The following is a description of a gene set: species: Mus musculus Mouse Gene Set: GOBP_RESPONSE_TO_UV_C Any process that results in a change in state or activity of a cell or an organism (in terms of movement, secretion, enzyme production, gene expression, etc.) as a result of a UV-C radiation stimulus. UV-C radiation (UV-C light) spans the wavelengths 100 to 280 nm., and this is the list of marker genes: Map3k4, Wrn, Brca2, Poli, Hmgn1, Dcun1d3, Ei24, Bak1, Pierce1, Trp53, Mdm2, Yy1, Polh, Bcl3, Ercc5